Given this list of marker genes Abca5, Nfkbia, Samd1, Stat1, Ep300, Prkch, Pla2g3, Nfkb1, Wnt5a, Pparg, Agt, Pla2g5, Ldah, Alox8, Crp, Soat1, Itgav, Il18, Mapk9, Cd36, Selenok, Apob, Adipoq, Tnf, Csf1, Lpl, Agtr1b, Csf2, Msr1, Hbp1, Abcg1, Itgb3, Il1b, Ppara, Agtr1a, here is a description of the gene set: Mouse Gene Set: GOBP_FOAM_CELL_DIFFERENTIATION species: Mus musculus The process in which a relatively unspecialized cell acquires the specialized features of a foam cell. A foam cell is a type of cell containing lipids in small vacuoles and typically seen in atherosclerotic lesions, as well as other conditions.